Given this list of marker genes Svip, Prkn, Bard1, Dph3, Cd36, Siah3, Ucp2, Bag3, Map4k4, Usp17le, Insig1, Ffar2, Rab11fip3, Ghsr, Rhbdf1, Adipoq, Dmtn, Sfrp1, Lrrk2, Sp100, Itgb1bp1, Crhr2, Mtnr1b, Eny2, Inpp5k (NCBI Gene Id 192772), Pde8b, Vsnl1, Inhbb, Anxa5, Srebf1, Il12b (interleukin 12b), F2rl1, Nf1, Ppp3ca, Kcnj6, Hnf4a, Mdfic, Mup2, Nr1h3, Yod1, Stxbp5l, Pkia, Midn, Cabp1, Srcin1 (NCBI Gene Id 56013), Rab11fip1, Derl2, Sirt6, Csk, Ei24, Fbn1, Snx12, Adra2a, Sergef, Drd3, Ywhab, Pde3b, Apoe, Txn1, Uts2, Irs1, Kcnb1, Cdk5, Ube2g2, Fam76b, Oprm1, 4930550C14Rik, Ifnb1, Il1b, Kcnq1, Drd4 (NCBI Gene Id 13491), Rptor, Erp29, Rab11fip5 (NCBI Gene Id 97286), Klf7, Psmd9, Gdi1, Ubac2, Apod, Erlec1, Gnaz, Foxo1, Ccn3, Nfkbia, Ndfip1, Cyp51, Ins1, Ghrl, Nos1, Snx3, Gnao1, Mapt, Sirt4, Derl3, Ptprv, Sumo1, Pim3, Bag4, Ufm1, Chga, Gbp4, Mup1, Wwp2, Pde4c, Fkbp1b, Pde1c, Ptpmt1, Fermt1, Ube2j1, Chp1, Kcne1, Angpt1, Lyplal1, Abcc8, Jagn1, Terf1, Hadh, Os9, Sytl4, Frmd4a, Mup5, Adtrp, Rhbdf2, Rsad2, Madd (MAP-kinase activating death domain), Neo1, Hdac3, Npff, Mtnr1a, Idh2, Ptpn11, Fam3d, Rangap1, Mup4, Kcnj11, Pkdcc, Coro2b, Gnai1, Drd2, Anxa1, Rab23, Ppm1f, Ins2, Akap1, Mup3, Syt4, Cd200, Ffar3, Pkig, Lypla1, Pfkl, Ptger3, Ndufaf2, Hmgcr, Nol3, Acvr1c, Il12a, Mup11, Idua, Dnaja1, Ogt, Tbc1d1, Park7, Rest, Ndfip2, F2r, here is a description of the gene set: Any process that stops, prevents or reduces the frequency, rate or extent of establishment of protein localization. Mouse Gene Set: GOBP_NEGATIVE_REGULATION_OF_ESTABLISHMENT_OF_PROTEIN_LOCALIZATION studied in species Mus musculus